The following is a description of a gene set: species: Homo sapiens from publication Fan X, Dong J, Zhong S, Wei Y, Wu Q, Yan L, Yong J, Sun L, Wang X, Zhao Y, Wang W, Yan J, Wang X, Qiao J, Tang F (PMID 29867213) Human Gene Set: FAN_EMBRYONIC_CTX_OLIG, and this is the list of marker genes: SLAIN1, TMEM64, ZFAND5, RAB21, PLEKHH1, BORCS5, STX6, ANO4, BPNT2, CYP2J2, S100B, SEMA3D, TMEM123, ASB1, FAXDC2, PITPNA-AS1, SERINC5, CCDC90B, GSN-AS1 (NCBI Gene Id 57000), PSEN1, RASGRF2, FAM174A, HIPK2, SELENOW, SELENOI, SIK3, SPATA2, C11orf58, FNIP1, SETD7, CFAP95, RHOG, ADCY5, VKORC1L1, NKX6-2, SH3KBP1, AMBRA1, LINC00467, CLCA4, PTK2, CYB5R2, BZW2, FAM13C, NUAK1, ARL2, ZNF189, BACE1 (NCBI Gene Id 23621), SHKBP1, BACE2, TIGAR, KATNIP, CLCN4, ELAPOR2, FEZ1, DTD2, PLAT, STX4, SOX2-OT, JOSD2, ROGDI, AIDA, FOLH1, WIPI1, TCP11L2, CARNS1, PEX5L, COL16A1, KLF13, PAIP2B, CEP104, GJB1, MCAM, NIPA1, MOG (myelin oligodendrocyte glycoprotein), CMTM5, KCNJ2, VSTM2B, P2RX7, NFASC, FNTA, PCP4, NOL4L, TSEN15, C1orf198, ANKRD44, ADCK2 (NCBI Gene Id 90956), SIRT2, CHN2, NECTIN1, NEK7, CILK1, SLCO3A1, NGFR, MYLK, MYO1D, ERBB3, ELOVL7, BMP8A, HMGCS1, RICTOR, C11orf71 (chromosome 11 open reading frame 71), QDPR, DACT3, PEDS1, PLD1, SLC22A23, ZDHHC11, C1orf122, TULP4, TOM1L2, SPTLC2, DIP2B (disco interacting protein 2 homolog B), HAPLN2 (hyaluronan and proteoglycan link protein 2), MINDY3, HEYL, RNF130, LINC03013, SLC4A2, FA2H, DNAJC6, OPALIN, AGPAT4, LARP6, NACAD (NCBI Gene Id 23148), CD200, TRIP12, AATK, PREX1, PIGG, MAST3, MOSPD2, EVI2A, CYLD, FLNB, ANKRD40, TTYH2, UBE2E2, REEP3, SEC14L5, NKAIN2, LIPA, PDE3B, SLC24A2, GNG7, KLHL32, SLC35A5, SOX8, TMEM50A, MTMR10, TMBIM1, CTNNA3, IGSF8, GAB1, INPP5A, HSD3B7, KCTD8, SLC16A8, LPAR1, PTPRD, MANEA, PCSK7, VWA1, H2BC21, CREB5, MEGF9, COBL, GLTP, RHOU, SLCO1A2, GOT1, CLMN (calmin), AOPEP, ADIPOR2, KLHL21, SORT1, TJAP1, SYNGR2, SHTN1, DESI1, SNX30, MAP4K4, FDFT1, TMEM184B, NINJ2, C21orf91, STMN4, CYP51A1, RTKN, COPS2 (NCBI Gene Id 9318), DEPTOR, PLPP1, DOCK10, NUDT12, PHLDA3, MBP, LGI3, ADAMTS18, CTTN, STIM1, RBM48, MOBP, TESK2, ELAVL3, PLLP, HOOK3 (hook microtubule tethering protein 3), SLC6A9, H2AJ (NCBI Gene Id 83739), BIN1, CNTN2, MAP1LC3B, SAMD12, TSC22D3, SH3TC2, LANCL1, C12orf76, PLEKHB1 (NCBI Gene Id 58473), NLRP14, POMGNT1, PIK3IP1, MAPK6, TOGARAM1, UNC5B, SCAMP5, ABCA2, GRIN2A, RALY-AS1, TMEFF2, GALNT6, ITPKB, FRY, SBDS, TMEM144, ATL3, NTM-AS1, LIMD1, MAN2A1, LINC01170, ENPP6, UNC5C, TAF10, SLC6A15, SESN1, JPT2, NAV2, BLOC1S2, PKP4, RNASE1, RCBTB1 (RCC1 and BTB domain containing protein 1), TPPP, ATP5F1E, MAPRE2, FAM222A (family with sequence similarity 222 member A), TBC1D9, ERMN, FAM107B, ZNF160, ANK3, NIPSNAP3A, SLC31A2, KIF13A, TRAM1L1 (translocation associated membrane protein 1 like 1), RAB11B-AS1, DNM2, ANKS1B, GRB10, APP, LDLR, HBEGF, MGAT5, CDR2L, RHOB, TSPAN9, OLIG2, HR, ZEB2, SLC45A3, BCAR1, SLC18A2, EDIL3 (EGF like repeats and discoidin domains 3), HMOX2, GARRE1, NENF, CCNY, MAPK8IP1, SEPTIN4, KLK6, ST6GALNAC3, ATP6V0B, ARHGAP22, SYNJ2, PRDM2, PLP1, GAREM1, SLC13A3, USP12, PRKAR1A (protein kinase cAMP-dependent type I regulatory subunit alpha), GAL3ST1, TMTC1, CLDN11, PFDN2, KCNMB4, EPS15, ELOVL6, IFNGR1, SAMD8, LCOR, AMOTL2, SEPTIN10, UBE2Z, PCBP4, GDE1, NCOA7, UBE4B, PIP4K2A, ERRFI1, TMC6, SCG5, DNAJB2, ENPP2, DCTN1 (dynactin subunit 1), TECR, PRR18, ARHGAP23, SUSD6, ZFYVE19, PXK, GTDC1, SEPTIN8, APBB1, ENDOD1, CTNNA1, SILC1, MARCHF1, CNDP1, PRKCQ-AS1, A1BG, LRRC8D, NXPE3, FAM221A, ADAP1, SEMA4D, PDE1A, GNAI1, CORO2B, CLDND1, IGSF11, LZTS2, CBR1, COL4A5, ULK2, AQP6, GSN, ATG4C, CLCN3, PTGDS, LIG4, PRKCSH, PLOD3, PRRG1 (NCBI Gene Id 5638), AGPAT1, TTL, CLIC4, CNP, ADO, CDKN1C, PLEKHA1, SHISA4, LACTB2, PIP5K1B, PCSK6, RASA3, RASGEF1B, CDC42EP2, CAPN3, PM20D1, ZNF365, KCNJ10, MAP6D1, ZFP57, ACAN, FGFR2, DEGS1 (delta 4-desaturase, sphingolipid 1), GPR155, RPS6KA2, TSC22D4, BBX, ATP10B, TSPAN15, FRS3, TPRN (taperin), PELI1, MOB3B, LINC00323, MYO1E, GPRC5B, HDAC11, SHISA2, ERMP1, RGS3, FAH, ABHD17B, TMEM125, CLASP2, AGFG1 (ArfGAP with FG repeats 1), PAPSS1, OSTF1, NDUFAF3, PPP2R5B, ACSBG1 (NCBI Gene Id 23205), NEO1, TMEM128, EMC10, CDH19, FNBP1, TMEM132B, WNK1, PAK1, FAM177A1, TYRO3, UBE2H, CSRP1 (NCBI Gene Id 1465), GAS7, GIPC1, RAPGEF5, ANLN, ALAD, SLC12A2, BCOR, INTS13, FAR1, PPP2CB, TTLL7, TMTC2, PRIMA1, LAMP1, STIMATE, COPA, FECH, ABLIM2, CA14, MTMR7, HOXD1, MARCKSL1, CFL2, DYNC1I2, SRSF8, DIXDC1, KANK4 (NCBI Gene Id 388637), NCOR2, RRBP1, RTN4, RAP2A, MYRF, GAMT, SOX10 (SRY-box transcription factor 10), FAIM, HAGLR, TIMP2, SLC22A6, C6orf47, LDLRAP1, NIPAL4, MITF, HSPA2, SYT9 (synaptotagmin 9), LMNA, ANO10, TJP2, CERS2 (ceramide synthase 2), ST3GAL5, RELT, BTBD16, STRN, RCAN1, TMEM178A, LHPP, BEST1, PPP1R16B, TRIM2, CA2, ZSWIM6, UBE2Q1, SGK2, DOCK9, IKZF5, ACER3, SMIM13, SRD5A3, CLN8, MAL, SNX29, MBNL2 (NCBI Gene Id 55479), ATP1B1, CTSV, CD9, SMAD7, ZNF536, KDM4C, GALNT15, JAM3, MPV17L2, PPFIBP2, SLC7A14, THEMIS2, NBR1, DNAJC12, ENPP4, ETV6, PHYHIPL, H1-2, ZFYVE28, FBN1, SMURF1, MAP7, MANSC1 (MANSC domain containing 1), GPR37, LDB3, EPB41L2, WASHC5, RYBP, PAQR6, EGLN3, ASPA, PLPP2, FMNL2, GJC2, DHCR24, TMEM151A, C4orf33 (chromosome 4 open reading frame 33), KBTBD3, APIP, GAS6, ARHGEF10, RNF103, COLGALT2, MAG (NCBI Gene Id 4099), S1PR5, PRICKLE1 (prickle planar cell polarity protein 1), EML2, DTNB, FAM124A, KIF13B, NDRG1, RASGRP3, RAB40B, INF2, ETFRF1, UGT8 (NCBI Gene Id 7368), MICALL1, DUSP10, AGPS (alkylglycerone phosphate synthase), PADI2, FRYL, TMEM230, MAP1A, GAB2, PAIP2, TBC1D12, SCARB1, MFSD14B, MPP2, RALGDS, KLHL24, APCDD1, SCARB2, PACS2, STAMBP, PICALM, SSH2, SPSB1, ATP9B, CHAMP1, RAB9A, FADS1, DNAAF9, SPOCK3, SPATA13, TMTC4, CPOX, KIAA0930, LINC01770, UNC13B (NCBI Gene Id 10497), PACRG-AS3, TNS2, APLP1, SPNS2, PDXP, STK39, YPEL2, SYT11, AZGP1, CANT1, SMPD1, DENND5A (DENN domain containing 5A), ATF7, PDE8A, AGAP1, KRT16P1, TSPAN19, DLG1, SFT2D1, PLAAT3, PTPDC1, SLC22A15, TMEM63A, BRSK1, ZDHHC9, LPGAT1, TPD52, AMPD3, MVB12B, ROPN1, CSF1, ABHD17A, TNS3, SERINC1, RXRG, MARCHF2, SGCB, EPB41L3, FAIM2, SEPHS2, CDK18, TARS3 (threonyl-tRNA synthetase 3), QKI, MFSD6, ACSL1, GOLGA7, RNF220, TXNDC9, CD164, HTATIP2, CDKN2AIPNL, PACC1, RRAS2, ZCCHC17, SVIP, ST18, DUSP26, ELL2, SFTPC, ELOVL1, SPTSSA, BCAS1, TF, SERPINI1, IL6ST, GPR62, TP53INP2, DNAJA4, MFSD12, PSD3, TFEB, DLG2, CDC42SE1, UBR1, PPP1R14A, ANKH, APOD, MIGA1, FUT8, MTMR2, PTP4A2, ADAMTS4, KTN1, PRKACB, RETREG1, CAHM, ZER1, SCD, SLC25A46, RAP1A, TCTA, VAMP3, NIPAL3, CRYAB, PHLDB1, TUBB4A, DUSP7, ZNF488, KIF1A, BROX, LDLRAD4 (NCBI Gene Id 753), DNM3, ABHD6, FAM131B, MTRR, BOK, RASSF2, HHIP, PLXNB3, MPC1, ZNF146, AMER2, LAMP2, FBXO32, CNTN1, TECPR2, ORMDL2, MTUS1, TRIM62, CD47, RAB33A, SNHG9, C5orf15 (NCBI Gene Id 56951), PLEKHG3, CHADL, ARHGEF37, EEIG1, SLC27A4, UBL3, TMEM256, TMCC3, TLCD5, OSBPL1A, RRAGC, ARHGEF2 (Rho/Rac guanine nucleotide exchange factor 2), CCNYL1, PABIR1, LRRC8B, LASP1NB, TMEM209, MAP7D1, ATP8A1, ADIPOR1, RNF13, BTBD3, FRMD4B, GLDN, DNAH17, CPD, CDK17, HID1, NPC1, CPM, SUN2, VMP1, APLN, SECISBP2L, PDE4DIP, PPP2R2A, PGAP4, SH3GL3, ARPC5, PLA2G4C, SLC44A1, TMCC2, CD22, IL1RAPL1, PHC2, SAV1, GALC, FIS1, IPO13